The following is a description of a gene set: The process in which an actin filament is broken down into smaller filaments. species: Mus musculus Mouse Gene Set: GOBP_ACTIN_FILAMENT_SEVERING, and this is the list of marker genes: Svil, Scin, Avil, Cfl1, Myh9, Vil1, Vill, Cfl2, Srgap2, Flii, Dbnl, Dstn, Csrp3, Capg, Gsn, Gmfg, Gmfb, Fmnl1